Given this list of marker genes JTB, SMYD5, PAX5, MAPK13, AZIN1, EMILIN2, FBXO10, CHTF8 (NCBI Gene Id 54921), CYP2S1, KAZN (kazrin, periplakin interacting protein), ASIC1 (NCBI Gene Id 41), FBXO41, POU2F2, GPC2, TMEM259, GNG13, G6PC3, PELATON, BACH2, IQSEC2, DLG2, IGF1, MECR, TBC1D5, SLC30A3, GTPBP2, TRAF3, STEAP4, FBXL5, SLC6A20, FGF23, RCN3, CSTPP1, ITPR3, SUPT16H, LZTS2, POM121, MPRIP, PRKD2, HIPK2, CHRNA10, MAPRE2, ARRB1, GGCX, CX3CR1, RPS6KA2, KDELR1, CPLX2, ACTR1A, PRKCSH, RBM23, C1RL, PRAF2, SP7, SLC25A23, CLIP3, TTC9, SPNS2, ALG9, PRR30, SGMS1, RCAN2, RAB6B, FAM163B, POM121C (NCBI Gene Id 442581), MLC1 (NCBI Gene Id 654039), POLDIP3, LCNL1, TMEM104, CDKN2AIP, MERTK, SDC3, VWA1, GTF2I, TMEM87A, BCAM, PARL, KIF21B, HLA-DQB2 (NCBI Gene Id 3120), IL31RA, PLEKHG4B, SMOC2, PPP3CB, MTHFR, SHPK, MECP2, TRIP12, HDAC11, WDR48, GAS7, LAMP5, ZNF322, PPT2, NECTIN1, H1-7, TRPV4, COL23A1, ASAP3, MTCL2, ALPG, ZNF343, MRPS11, IQSEC3, BEST1, TMEM229B, CGREF1, OSBP2, here is a description of the gene set: Human Gene Set: MIR1227_5P Genes predicted to be targets of miRBase v22 microRNA hsa-miR-1227-5p in miRDB v6.0 with MirTarget v4 prediction scores > 80 (high confidence targets). from publication Chen Y, Wang X (PMID 31504780) studied in species Homo sapiens